The following is a description of a gene set: Reactome Pathway: GRB7 events in ERBB2 signaling studied in species Mus musculus electronically inferred by orthology from the curated human pathway part of: Signaling by ERBB2 This event has been computationally inferred from an event that has been demonstrated in another species.<p>The inference is based on the homology mapping from PANTHER. Briefly, reactions for which all involved PhysicalEntities (in input, output and catalyst) have a mapped orthologue/paralogue (for complexes at least 75% of components must have a mapping) are inferred to the other species., and this is the list of marker genes: Erbb2